Given this list of marker genes NOLC1, ANG, TM4SF19, FAM135B, CPSF6, ARL8A, APRG1, MORF4L2, SLC26A4, ZNF606, TRDN (triadin), SLFN12, TENT4A, GCA, PIGA, SLC16A14, RGL2, LPL, NEMP1, ZNF23, MBD4, VSNL1, PURA, GRIK2, XIRP2, VDAC1, KCNMB4, ARHGAP26, MEOX2, PDXDC1, ZFR, ANKRD26, TSPYL4, CLVS1, MS4A14, KMT2A, ZNF454, BEND4, DYNC2H1, PHF23, PDCD2, ZNF85, ATP5MG, ZNF282, BTNL9, KCNK2, CFAP47, BBS7, NCAPG2, RANBP3L, TMIGD3, ABHD10, NPAS3, TTLL5, ZFHX4, IGF2R, PROSER1, FOXP1, SIM1, PTPRC, CDK14 (NCBI Gene Id 5218), COCH, TJP2, C6orf120, PNP, PTGR2, SET (SET nuclear proto-oncogene), MAMDC2, RNF144A, CALML4, LRRC19, PGM5, CCNT2, TBC1D9B, MANBA, C12orf75, KLHL29, CEP44, EPHA3 (NCBI Gene Id 2042), here is a description of the gene set: Genes predicted to be targets of miRBase v22 microRNA hsa-miR-6755-3p in miRDB v6.0 with MirTarget v4 prediction scores > 80 (high confidence targets). species: Homo sapiens from publication Chen Y, Wang X (PMID 31504780) Human Gene Set: MIR6755_3P